The following is a description of a gene set: studied in species Homo sapiens Abnormally reduced levels of aldosterone. Human Gene Set: HP_DECREASED_CIRCULATING_ALDOSTERONE_CONCENTRATION Decreased circulating aldosterone concentration, and this is the list of marker genes: NNT (NCBI Gene Id 23530), TRAPPC11, AAAS, TXNRD2, CYP17A1, GMPPA, NR0B1, STAR (NCBI Gene Id 6770), CYP11B1, MRAP, MC2R, NR3C2, HSD3B2, CYP11A1, SCNN1A, HSD11B2, AIRE, CYP11B2, SCNN1G, SCNN1B, NR3C1